The following is a description of a gene set: part of: Signaling by ERBB2 electronically inferred by orthology from the curated human pathway This event has been computationally inferred from an event that has been demonstrated in another species.<p>The inference is based on the homology mapping from PANTHER. Briefly, reactions for which all involved PhysicalEntities (in input, output and catalyst) have a mapped orthologue/paralogue (for complexes at least 75% of components must have a mapping) are inferred to the other species. Reactome Pathway: Drug-mediated inhibition of ERBB2 signaling studied in species Mus musculus, and this is the list of marker genes: Cdc37, Erbb2